Given this list of marker genes HRAS, LEFTY2, EGF, ZNF423, STAT1, TFE3, SMAD5, ITGB6, BAMBI, EP300, SMAD7, SKIL, IFNG, ZFYVE9, LIF, RUNX2, ENG, LEF1, SMAD3, TGFBR2, NFKB1, SKI, CTNNB1, SMAD9, THBS1, FST, NOG, MAPK3, ZEB2, TGIF1, LTBP1, SMAD1, RUNX3, FOXH1, TGFB1, BMP4, JAK1, MIR302A, SMAD6, SPP1, LEFTY1, CREBBP, SMAD2, STAT3, TGFBR3, MAPK9, FOS, JUN, SMAD4, TGFBR1, INHBA, WNT1, TNF, SERPINE1, FKBP1A, here is a description of the gene set: Human Gene Set: WP_TGFBETA_RECEPTOR_SIGNALING studied in species Homo sapiens TGF-beta receptor signaling